The following is a description of a gene set: A protein complex required for the biogenesis of specialized organelles of the endosomal-lysosomal system, such as melanosomes and platelet dense granules. Many of the protein subunits are conserved between mouse and human; the mouse complex contains the Pallidin, Muted, Cappuccino, Dysbindin, Snapin, BLOS1, BLOS2, AND BLOS3 proteins. Human Gene Set: GOCC_BLOC_1_COMPLEX species: Homo sapiens, and this is the list of marker genes: BLOC1S4, SNAP25, PI4K2A, BLOC1S2, BLOC1S3, BLOC1S1, STX12, KXD1, BLOC1S5, BCAS4, SNAP47 (NCBI Gene Id 116841), SNAPIN, DTNBP1, WASHC4, BLOC1S6